Given this list of marker genes RPS13 (ribosomal protein S13), RPS25, RPS20, FAU, RPS17, RPS12, RPS3A, RPS11, RPS2, RPS8, RPS4Y1, EIF3E, RPS5, PABPC1, RPS24, RPS29, EIF3I, EIF2S1, RPS18, EIF3M, RPSA, EIF3F, RPS28, 18S rRNA, EIF3D, EIF4E, EIF3B, RPS3, RPS4Y2, RPS21, EIF2S2, RPS23, EIF3H, EIF1AX (NCBI Gene Id 83754), RPS15, RPS14, RPS10, EIF4H, RPS16, RPS27A, EIF3C, EIF4A1, EIF4G1, EIF4A2, EIF3J, RPS6, EIF3L, EIF3G, RPS26, RPS15A, EIF2S3, RPS7, EIF3K, RPS27L, RPS27, EIF3A, RPS19, EIF4B, RPS9, RPS4X, here is a description of the gene set: Reactome Pathway: Translation initiation complex formation part of: Activation of the mRNA upon binding of the cap-binding complex and eIFs, and subsequent binding to 43S The translation initiation complex forms when the 43S complex binds the mRNA that is associated with eIF4F, eIF4B and eIF4H. eIF4G in the eIF4F complex can directly contact eIF3 in the 43S complex. eIF1A is necessary for the formation of this complex. species: Homo sapiens